The following is a description of a gene set: species: Homo sapiens Recurrent cutaneous fungal infections Increased susceptibility to cutaneous fungal infections, as manifested by recurrent episodes of cutaneous fungal infections. Human Gene Set: HP_RECURRENT_CUTANEOUS_FUNGAL_INFECTIONS, and this is the list of marker genes: STAT3, IKBKB, RORC, TP53 (tumor protein p53), IKBKG, GJB6, IL6ST, IL2RG, WDR1 (WD repeat domain 1), BRAF, PIK3CD, JAK3, USP8, IL7R, CD247, MAP3K14, CD40LG, KNSTRN, ZNF341 (NCBI Gene Id 84905), DOCK2, TLR8, CIITA, NCF2, MVK, IL17RA, FOXN1, PSMB10, SP110, EPG5, PGM3, TRAF3IP2, RFXANK, GJB2, LCK, CARD9, CD3G, CARMIL2, USP48, CLEC7A, RFXAP, RFX5, TFRC, ATRX, ITGB2, AP3B1, CD3E, STAT1, SREBF1, IL17RC, NR3C1, CORO1A, CD3D, TRAC, DCLRE1C, STK4, ADA, IL2RA, NFKBIA, AIRE, IL17F, ZAP70, CDH23